Given this list of marker genes Foxn3, Smarcc2 (SWI/SNF related, matrix associated, actin dependent regulator of chromatin, subfamily c, member 2), Tm4sf5, Birc5, Plcb1, Zfp830, Cdca5, Cdc25c, Cdk3, Stxbp4, Stox1, Dcun1d3, Atr, Larp7, Gnb1l, Rint1, Trrap, Klf11, Anapc15-ps, Ercc2, Ctdsp2, Cdc14a, Atf5, Nek11, Abraxas1, Ccnd2, Anp32b, Pcid2, Rcc2, Smarca2, Wnt10b, Prap1, Ccl12, Wee1, Kif14, Gpr132, Fbxo31, Stk33, Trip13, Arid1a, Crebbp, Bub1b, Btn2a2, Zfp207, Cdk2, Acvr1, Plpp2, Ppp2r3d, Ino80, Ccnd3, Cep63, Brca2, Mn1, Tert, Paf1, Pten, Kcnh5, Zfyve19, Mir26a-2, Actl6a, Usp17le, Ddb1, Lsm10, Rbbp8, Cdk5rap3 (NCBI Gene Id 97738), Ddx3x, Fem1b, Nuf2, Nsmce2, Gpnmb, Dpf1 (double PHD fingers 1), Rrm1 (ribonucleotide reductase M1), Zfy2, Men1, Cacnb4, Tfap4 (NCBI Gene Id 83383), Creb3l1, Mir26a-1, Cdc20, Mus81, Mir124a-2, Lcmt1, Ccne1, Wdr76, Rbl1, Apbb2, Smarcd2, Ankrd17, Fzr1, Slfn1, Bard1, Xpc, Cdc5lrt7, E2f1, Actl6b, Mdc1, Myo16, Ptprv, Brcc3dc, Cenpf, Chfr, Rassf1, Map3k20 (NCBI Gene Id 99253), Fgf10, Rfwd3, Mnat1, Usp28, Nae1, Eif4g1, Klhl22, Hormad1, Mbtps1, Mre11a, Appl2, Crnn, Spc24, Ik, Cdkn1a, Nek10, Vps4a, Bcl7a, Tpra1, Ier3, Cdc5lrt10, Rhno1, Plrg1, Dot1l, Pabir1, Stk38, H2ax, Anxa1, Tpr, Nbn, Hsf1, Smarcb1, Tti1, Prmt2, Rab11a, Inhba, Cul4a, Zfp36l2 (NCBI Gene Id 12193), Adam17, Mettl13, Actb, Plk1, Clspn, Ccnq, Nabp1 (NCBI Gene Id 98468), Cdk17, Cdc16, Cdkn2c, Ercc6, Aurka (aurora kinase A), Cdc14b, Ezh2, Susd2, Lmnb1, Csf1r, Ccne2, Eme1, Diaph3, Chek2, Arid2 (NCBI Gene Id 77044), Ccnd1, Rptor, Pdik1l, Eme2, Smarce1, Rrm2b, Cdk4, Ndc80, Timeless, Cdk18, Klf4 (NCBI Gene Id 269540), Atf2, Rbl2 (NCBI Gene Id 19651), Usp47, Apbb1, Pkd1, Aif1, Neurog1, Etaa1, Cenpe, Tex14, Knl1, Mbd4, Lyn, Appl1, Ctc1, Fbxo7, Rad51c, Smarcc1, Gjc2, Topbp1, Ppp2ca, Cdkn2a, Usp44, Cyp1a1, Gas1, Anapc5, Id2, Jade1, Nek6, Zc3h12d, Ints3, Brd4, Inip, Tgfb1, Fhl1, Ube2u, Sass6, Pkmyt1, Chmp4c, Eif2ak4, Foxo4, Npm1, Cdk10 (NCBI Gene Id 234854), Dtx3l, Mos, Mad1l1, Mrnip (MRN complex interacting protein), Usp50, Cdk1, Pagr1a, Dact1, Ddr2, Rad17, Npm2 (NCBI Gene Id 328440), Pbrm1, Cul3, Rad51, Mad2l1, Ticrr, Nop53, Gen1, Ptpn11, Rgcc, Cdc25a, App, Rad50, Ing4, Miip, Anapc7 (NCBI Gene Id 56317), Rpl24, Crlf3, Cdc6, Pkd2, Mapk14, Cul4b, Ctdspl, Fbxo5, Cdk5rap2, Plk3, AY074887, Plcg2, Cdk14, Mta3, Cdc5l, Fam107a, Dyrk3, Tcf3, Rps27l, Psme3, Smarca4, Pkp3, E2f7, Zwilch, Smarcd1, Dbf4, Bcl2, Phf10, Ccnb1-ps, Trp63, Incenp, Vps4b, Aurkb, Pkia, Ube2c, Fancd2, Bcl7b, Dgkz, Rad1 (RAD1 checkpoint DNA exonuclease), Aven, Anapc15, Parp9, Cdkn1b, Trim39, Trex1, Orc1, Babam2, Mad2l1bp, Brcc3, Ska1, Pbx1, Cdc5lrt4, Tbx1, D1Pas1, Mtbp, Prkdc, Ecd, Camk2d, Cdc23, Rpl17, Cdc5lrt5, Zfp655, Taok2, Ttk, Senp2, Donson (downstream neighbor of SON), Dpf3 (double PHD fingers 3), Mir26b, Hinfp, Ints7, Rb1, Brsk1, Stil, Prkcq, Atp2b4, Rad9a, Sin3a (transcriptional regulator, SIN3A (yeast)), Kcna5 (NCBI Gene Id 213586), Cirbp, Psmg2, Gpr15lg, Syf2, Rpa2, Cdc5lrt1, Zw10 (zw10 kinetochore protein), Mblac1, Cdt1 (NCBI Gene Id 97441), Tiprl, Ccng1, Tcim, Atad5, Apc, Adamts1, Nabp2, Anapc11, Rnaseh2b (ribonuclease H2, subunit B), Cdc73, Uimc1 (ubiquitin interaction motif containing 1), Cry1, D7Ertd443e, Spdl1, Apbb3, Gigyf2 (NCBI Gene Id 98689), Bid (NCBI Gene Id 72579), Cdk16, Dlg1, Hus1b (NCBI Gene Id 210554), Clock, Hyal1, Khdc3 (NCBI Gene Id 66991), Nek1, Sde2, Ovol1, Dna2, Rrm2, Egfr, Lsm11, Spc25, Prpf19 (NCBI Gene Id 28000), Smarcd3, Six3, Ccar2, Msh2, Bub1, Cdkn2d, Paxip1, Cdca8, Kank2, Apex1, Ccnh, Cdk5, Tbx2, Klhl18, Kntc1, Fbxo4, Cdc5lrt9, Mepce, Hspa2, Mlf1, Psme1, Stk35, Rdx, Phb2, Cdkn2b (cyclin dependent kinase inhibitor 2B), Fam83d, Cdc25b, Hecw2, Xrcc3, Dtl, Ctdsp1, Prpf4b, Dpf2, Cenpj, Brd7, Ambra1, Macroh2a1, Atrip, Zfp36l1, Pinx1, Anapc4, Mbtps2 (membrane-bound transcription factor peptidase, site 2), Cdk6, Blm, Cpsf3, Brca1, Psme2, Dync1li1, Chek1, Cdc7, Akt1, Mdm2, Pdpn, Ska3, Plk5, Bub3, Ufl1, Cep192, Ercc3, Atm, Ube2e2, Wac, Rps6, Arhgap33os, Nsun2, Tmsb4x, Tfdp1 (NCBI Gene Id 21781), Cdk7, Rad51b, Mapk15 (mitogen-activated protein kinase 15), Tipin, Ppp1r10, Tjp3, Cdc5lrt6 (NCBI Gene Id 668203), Rad21, Mir124a-1, Taok1, Taok3, Sox2, Setmar, Cdk2ap2, Zwint, Haspin, Kmt2e, Dusp1, Trp53bp1, Gli1, Riok2, Ccnb1, Cdk15, Cdc5lrt8, Tmod3, Bcl7c, Babam1, Hacd1, Prox1, Trp53, Ubd, Mir124a-3, Ptpn6, Hus1, Cdkn1c, Rad9b, here is a description of the gene set: species: Mus musculus Any process that modulates the frequency, rate or extent of cell cycle phase transition. Mouse Gene Set: GOBP_REGULATION_OF_CELL_CYCLE_PHASE_TRANSITION